The following is a description of a gene set: Mouse Gene Set: GOBP_CELL_MIGRATION_IN_HINDBRAIN studied in species Mus musculus The orderly movement of a cell that will reside in the hindbrain., and this is the list of marker genes: Sema4c, Rere, Atp1b2, Nhlh2, Phox2b, Plxna2 (plexin A2), Rbfox2 (NCBI Gene Id 93686), Ttbk2, Cul5, Rnf7, Pou4f1, Lrp6, Ctnna2, Flna, Ulk1, Ephb2, Dab1, Lef1, Cend1, Ephb1, Socs7, Arl13b, Itgb1